The following is a description of a gene set: The volume enclosed by the membranes of the sarcoplasmic reticulum. Human Gene Set: GOCC_SARCOPLASMIC_RETICULUM_LUMEN studied in species Homo sapiens, and this is the list of marker genes: HSP90B1, ASPH, HRC, CASQ2, MANF, TRDN, SRL, CALU, CASQ1, CALR